Given this list of marker genes OSM, LMBR1L (NCBI Gene Id 55716), FBXO21, SRF, BCL2, ACE, METTL3, SH2B3, TMSB4X, EIF2AK2, TAL1, SETD1A, PUS7, KAT5, BATF, MED1, YTHDF2, TP53, CHD2, PRKDC, HSPA9, CDK6, ITCH, SFRP1, HOXB4, NFE2L2, MLLT3, ABL1, UFL1, XRCC5, SP7, N4BP2L2, FOXC1, TCF15, MEOX1, ERCC2, EXT1, here is a description of the gene set: studied in species Homo sapiens Human Gene Set: GOBP_HEMATOPOIETIC_STEM_CELL_DIFFERENTIATION The process in which a relatively unspecialized cell acquires specialized features of a hematopoietic stem cell. A stem cell is a cell that retains the ability to divide and proliferate throughout life to provide progenitor cells that can differentiate into specialized cells.